The following is a description of a gene set: species: Homo sapiens Human Gene Set: GOBP_TELENCEPHALON_DEVELOPMENT The process whose specific outcome is the progression of the telencephalon over time, from its formation to the mature structure. The telencephalon is the paired anteriolateral division of the prosencephalon plus the lamina terminalis from which the olfactory lobes, cerebral cortex, and subcortical nuclei are derived., and this is the list of marker genes: CRKL, PLXNA4, DRD1, POU3F3, LRP8, PIANP, BTBD3 (NCBI Gene Id 22903), KDM6B, GSK3B, DPCD, EZH1, ID2, SRD5A1, CHD7, TTC8, NEFL, NRG3, RPGRIP1L, C12orf57, CEP120, XRN2, MFSD2A, MYH10, EPHB2, SIX3, ATOH1, TFAP2C, BBS4, FKTN, CDK5 (NCBI Gene Id 1020), BLOC1S6, INHBA, RHOA, BBS2, FEZ1, KCNA1, GART, MDGA1, NR4A3, NRGN, RARB, SYNE2, FOXP2, ROBO1, HTR6, ATF5, HIF1A, RELN, SLIT3, BBS1, CDH2, NTRK2, SLC38A2, VPS13B, ZDHHC16, KDM1A, SRGAP2C, BCL11B, CSNK2A2, SRD5A2 (NCBI Gene Id 6716), CDK5R2, NDEL1, TACC1, PTPRS, CRTAC1, EMX1, SALL1, PAX6, POMT2, CCDC141, DCLK2, NPY, RYK (receptor like tyrosine kinase), TP73, RFX4, RAN, ATP1A2, SCN5A, BCAN, TCTN1, ZEB2, FOXG1, MBOAT7, ZIC3, SLITRK5, DAB2IP, LHX1, ID4, WDR62, POMGNT1, TMEM108, RARA, BNIP3, TUBB2B, MKKS, CNTNAP2, FGF13, FBXO41, PEX5, SRF, KAT2A, PLXNA3, HES1, YWHAE, IGF2BP1, DLX2, ZSWIM6, NR2E1, ATP2B4, MDK, CORO1C, SUN1, COL3A1, AVPR2, DAB1, SECISBP2, FEZF1, TUBB2A, SCT, CRK (CRK proto-oncogene, adaptor protein), TMEM14B, RTN4R, ATG16L1, NSUN5, SEMA6B, AKIRIN2, NIN, SHH, NKX2-1, CASP3, FUT10, ARHGAP11B, GRIA1, ZIC1, SKI, EFHC1, LPAR1, DNAH5 (NCBI Gene Id 64774), LHX5, FAT4, OGDH, HES5, ROBO2, AQP1, AVPR1A, PLCB1, WDR89, RTN4RL1, BTG2, XAB2, ZMIZ1, PRDM8, RTN4, POU3F2, LHX6, PEX13, NEUROD6, FOXB1, HERC1, SLC32A1, SZT2, LHX2, EIF2B5, TUBA1A, NUMB, FLNA, BMP2, DLX5, TACC2, FUT1, DIXDC1 (NCBI Gene Id 85458), DLX1, SLC7A11 (NCBI Gene Id 23657), LMX1A, PALS1, FOS, PHLPP2, EGFR, AGTPBP1, SLC8A3, RTN4RL2, WDR37, CDK6, SLIT1, UNCX, NOTCH2NLB, ASPM, NCOA1, NF2, CDK5R1, PAFAH1B1, FOXP1 (NCBI Gene Id 87246), TRA2B, SLIT2, CSF1R, FILIP1, ATIC, FBXO45, LRRK2, CXCL12, PROX1, CTNNB1, RAC1 (NCBI Gene Id 5879), NUMBL, DRAXIN, GLI3, EOMES, LEF1, XRCC1, FEZF2, KCNC1, SLC1A2, NDE1, BAX, BMP4, CCDC39, PPP1R9B, TRAPPC9 (trafficking protein particle complex subunit 9), HTR5A (5-hydroxytryptamine receptor 5A), PSEN1, EFNA2, GSX2, LARGE1, NEUROD1, FXR1, SOCS7, MCPH1, EXT1, BMERB1, TACC3, DMRTA2, TSC1, P2RY12, SEMA3A, CNTN2, PTEN, FGF8, WNT3A, NOTCH2NLA, TBR1, CFL1, CDON, KCNA2, WDR47, KDM2B, EMX2, PAX5, ARL13B, NFIB, CCDC85C, WNT5A, SHANK3, ARX (aristaless related homeobox), HDAC1, ATAT1, SRGAP2, SMO, EZH2 (enhancer of zeste 2 polycomb repressive complex 2 subunit), SUN2, NARS1, GMPPA, TNR, KIRREL3, ATP1B2, ERBB4, DISC1, ASCL1, ADGRG1, KIF26A, PHACTR1, NF1, HPRT1, LAMB1, KIF14, MGARP, ALDH1A3, FXR2, EPHA5, TSKU, ALK, UQCRQ, SEMA7A, NOTCH2NLC, UCHL5, EPHB3, DRD2, SLC2A1